Given this list of marker genes AFF1, AFF4, EAF2, EAF1, AFF3, AFF2, here is a description of the gene set: A transcription elongation factor complex that increases the overall rate of RNA polymerase II transcription elongation by suppressing transient polymerase pausing. At minimum, the complex contains a transcription factor of the ELL family, an EAF protein, and an AFF family protein or distant relative and most likely also P-TEFb and AF9 or ENL. The complex is conserved from yeast to humans. In Schizosaccharomyces pombe it contains Ell1, Eaf1, and Ebp1, but it is absent from S. cerevisiae. species: Homo sapiens Human Gene Set: GOCC_SUPER_ELONGATION_COMPLEX